The following is a description of a gene set: Human Gene Set: HP_HEMIMEGALENCEPHALY Enlargement of all or parts of one cerebral hemisphere. Hemimegalencephaly studied in species Homo sapiens, and this is the list of marker genes: TSC1, NPRL2, DEPDC5, KRAS, HRAS, IFNG, NPRL3, NRAS, TSC2, PIK3CA (NCBI Gene Id 5290), PTEN, SMO, MTOR, AKT3